The following is a description of a gene set: species: Mus musculus Genes up-regulated in the uteri of ovariectomized mice 6 h after progesterone injection: HOXA10 knockout vs wild type animals. Human infertility and recurrent pregnancy loss caused by implantation defects are poorly understood. Hoxa-10-deficient female mice have severe infertility and recurrent pregnancy loss due to defective uterine implantation. Gene expression profiling experiments reveal that Hoxa-10 is an important regulator of two critical events in implantation: stromal cell proliferation and local immunosuppression. At the time of implantation, Hoxa-10 mediates the progesterone-stimulated proliferation of uterine stromal cells. Hoxa-10 mutants express a stromal cell proliferation defect that is accompanied by quantitative or spatial alterations in the expression of two cyclin-dependent kinase inhibitor genes, p57 and p15. Hoxa-10 deficiency also leads to a severe local immunological disturbance, characterized by a polyclonal proliferation of T cells, that occurs in place of the normal progesterone-mediated immunosuppression in the periimplantation uterus. Mouse Gene Set: YAO_HOXA10_TARGETS_VIA_PROGESTERONE_UP from publication Yao MW, Lim H, Schust DJ, Choe SE, Farago A, Ding Y, Michaud S, Church GM, Maas RL (PMID 12554760), and this is the list of marker genes: Peg3, Crip2, Gas6, Nr4a1, Car3, Wnt4, Shd, Eln (NCBI Gene Id 319426), Ces2g, Id1, Klk1b26, Adm, Lcn2, Cherp, Apoe, Igkv10-95, Slc27a1, Inmt, Hmgcr, Rem1, Dtd2, Cavin2, Flt1, Cyp2f2, Me1, Gsta3, Rarres2, Tnxb, Rnase4, Reg3a, Thbd, Cldn5, Atp1a2, Meis1, Klf10, Lama2, Cfd, Tns2, Gem, Klf9, Cdh16, Gstt1, Pik3r1, Ighg2b, Nbl1, Dbp, Senp6, Kcnab1, Thrsp, Tbx3, Cyp2e1, Akap8l (NCBI Gene Id 54194), H2-Ab1, Enpp2, Arl4a, Ncam1, Ltf, Gdpd3, Rnf227, Pdpn, Prpf39, Pros1, Aqp1 (aquaporin 1), Meg3, Igfbp3, Pagr1a, Csf3r, Actb, Trgc1, Bcl2, Ddx50, Ndrg2, Lepr, Scd1, Pbx3, Adipoq, Slc25a48, B3galnt1, Sertad1, Rbp1, Ttc14, Xdh, Cdkn1c, Idh2, Use1